The following is a description of a gene set: Human Gene Set: GOBP_REGULATION_OF_B_CELL_RECEPTOR_SIGNALING_PATHWAY Any process that modulates the frequency, rate or extent of signaling pathways initiated by the cross-linking of an antigen receptor on a B cell. studied in species Homo sapiens, and this is the list of marker genes: CD300A, FOXP1, PRKCH, CD19, GCSAML, PTPN6, PTPN22, SLC39A10, CMTM3, GPS2, MIR19A, PLCL2, CD72, LYN, LPXN (leupaxin), FCMR, FCGR2B, CD22, GCSAM (NCBI Gene Id 257144), NFAM1, MIR34A (microRNA 34a), MIR18A, FCRL3, STAP1, CD81